Given this list of marker genes Ifng, Lama2, Chrna3, Adora2a, Slc18a3, Nalcn, Tacr1, Htr2c, Tac1, Tacr2, Ngfr, Camk2b (calcium/calmodulin-dependent protein kinase II, beta), Musk, Htr6, Cacna1a, Uts2 (NCBI Gene Id 24111), here is a description of the gene set: species: Mus musculus Any process that modulates the frequency, rate or extent of cholinergic synaptic transmission, the process of communication from a neuron to another neuron across a synapse using the neurotransmitter acetylcholine. Mouse Gene Set: GOBP_REGULATION_OF_SYNAPTIC_TRANSMISSION_CHOLINERGIC